Given this list of marker genes Cct7, Cct3, Dkc1, Cct5, Cct2, Gnl3l, Cct8, Gnl3, Wrap53, Cct4, Pml, Cct6a, Tcp1 (t-complex protein 1), here is a description of the gene set: Any process that activates or increases the frequency, rate or extent of protein localization to chromosome, telomeric region. studied in species Mus musculus Mouse Gene Set: GOBP_POSITIVE_REGULATION_OF_PROTEIN_LOCALIZATION_TO_CHROMOSOME_TELOMERIC_REGION